Given this list of marker genes CDCA5, KAT2B, KIF2C, CHMP4C, PSRC1, CCNB1, SPDL1, CHAMP1, ANKRD53, MAD1L1, CDC23, CENPE, NUP62, NDC80, EML3, CENPC, PINX1, AURKB, CHMP2B, KAT5, NUDC, CHMP2A (charged multivesicular body protein 2A), CHMP3, SIRT1, CDT1, RRS1, SKA3, CHMP4A, VPS4B, CDCA8, ZW10, KIFC1, SKA1, SKA2, CCDC66, KIF14, RAB11A, KIF22, CHMP5, BOD1, CHMP4BP1, MIS12, INCENP, KPNB1, CHMP6, CEP55 (centrosomal protein 55), CHMP1A, BIRC5, NUF2, CHMP7, TTK, MAPRE1, PIBF1, VPS4A, CHMP1B, RMDN1, CUL3, EML4, BECN1, KIF18A, SEH1L, CHMP4B, HNRNPU, DCTN2, CDK1, PDCD6IP, here is a description of the gene set: studied in species Homo sapiens Human Gene Set: GOBP_MITOTIC_METAPHASE_CHROMOSOME_ALIGNMENT A chromosome localization process whereby chromosomes are positioned in a specific order and orientation at the metaphase plate (spindle equator), during mitotic chromosome segregation. This alignment ensures that each daughter cell will receive the correct number of chromosomes during cell division.